Given this list of marker genes PNKP, LIG3 (NCBI Gene Id 3980), NEIL2, NEIL1, POLB, XRCC1, OGG1, here is a description of the gene set: NEIL1 and NEIL2 have a dual DNA glycosylase and beta/delta lyase activity. The AP (apurinic/apyrimidinic) site-directed lyase activity of NEIL1 and NEIL2 is their major physiological role, as they can act on AP sites generated spontaneously or by other DNA glycosylases. NEIL1 or NEIL2 cleave the damaged DNA strand 5' to the AP site, producing a 3' phosphate terminus (3'Pi) and a 5' deoxyribose phosphate terminus (5'dRP). DNA polymerase beta (POLB) excises 5'dRP residue but is unable to add the replacement nucleotide to DNA with the 3'Pi end. PNKP, a DNA 3' phosphatase, removes 3'Pi and enables POLB to incorporate the replacement nucleotide, which is followed by ligation of repaired DNA strand by XRCC1:LIG3 complex. studied in species Homo sapiens part of: Resolution of Abasic Sites (AP sites) Reactome Pathway: APEX1-Independent Resolution of AP Sites via the Single Nucleotide Replacement Pathway